Given this list of marker genes ZMPSTE24, MTHFS, ADGRG6, PHGDH, LMNA, MUSK, here is a description of the gene set: Decreased length of the umbilical cord. Short umbilical cord Human Gene Set: HP_SHORT_UMBILICAL_CORD studied in species Homo sapiens